Given this list of marker genes TRBV30, EAF1-AS1, HFM1, NPIPB8, HYAL3, SLCO5A1, MEF2C-AS2, MIR3671, TRAV8-2 (NCBI Gene Id 28684), ZNG1E, TIMM23B, ORC1, IGKV2D-29, IGLV4-69, SULT1A3, ALAS2, here is a description of the gene set: studied in species Homo sapiens Human Gene Set: HOEK_PBMC_INACTIVATED_INFLUENZA_ADULT_3DY_UP Systems biology is an approach to comprehensively study complex interactions within a biological system. Most published systems vaccinology studies have utilized whole blood or peripheral blood mononuclear cells (PBMC) to monitor the immune response after vaccination. Because human blood is comprised of multiple hematopoietic cell types, the potential for masking responses of under-represented cell populations is increased when analyzing whole blood or PBMC. To investigate the contribution of individual cell types to the immune response after vaccination, we established a rapid and efficient method to purify human T and B cells, natural killer (NK) cells, myeloid dendritic cells (mDC), monocytes, and neutrophils from fresh venous blood. Purified cells were fractionated and processed in a single day. RNA-Seq and quantitative shotgun proteomics were performed to determine expression profiles for each cell type prior to and after inactivated seasonal influenza vaccination. Our results show that transcriptomic and proteomic profiles generated from purified immune cells differ significantly from PBMC. Differential expression analysis for each immune cell type also shows unique transcriptomic and proteomic expression profiles as well as changing biological networks at early time points after vaccination. This cell type-specific information provides a more comprehensive approach to monitor vaccine responses. Genes up-regulated in peripheral blood mononuclear cell 3d vs 0d in adults after exposure to Inactivated influenza vaccine, time point 3D. Comment: Up-regulated DE RNA transcripts (up >= 1.5x) shared between both TIV-vaccinated donors from publication Hoek KL, Samir P, Howard LM, Niu X, Prasad N, Galassie A, Liu Q, Allos TM, Floyd KA, Guo Y, Shyr Y, Levy SE, Joyce S, Edwards KM, Link AJ (PMID 25706537)